Given this list of marker genes SPRY1, TOR1A, PSMC1, GATA2, CCT4, GDPD5, VPS45, ODF1, ITGAE, LGALS8, RRAGD, CASP7, ABCA4 (NCBI Gene Id 7815), IK, RASSF2, TTTY2, LIMK2, EPB41L1, CHRNB4, MTOR, SBF1, ETV4 (ETS variant transcription factor 4), NUP88, FERMT2, NUP205, KIF21B, U2AF2, PIK3C3, N4BP2L2, MLXIP, GFRA2, RHOA, DPF2, GJB3, CORO1A, CACTIN, COPS5, VAV2, MDN1, USP13, ZYX, EIF2S1, ACACB, CD79A, JUND, DLGAP4, ENSG00000275616, KRT4, PART1, CMC4, LYPD1, TMEM131, ACSL3, FOS, GAA (alpha glucosidase), SFTPD, STARD3, here is a description of the gene set: Integrin signaling signature in precursor B leukemia (PBL) cells: fibronectin (FN1) vs control treatment with poly-L-lysine. studied in species Homo sapiens The physical interactions between B cells and stromal cells from the lymphoid tissue microenvironment are critical to the survival of normal and malignant B cells. They are principally mediated by integrins expressed on B cells and counterreceptors on stromal cells. Specifically, alpha4beta1 integrin engagement rescues B cells from physiological or drug-induced apoptosis. Therefore, in order to understand the mechanisms by which integrins prevent apoptosis in leukemia B cells, we compared the temporal gene expression profiles induced by beta1-integrin ligation with fibronectin (Fn) or adhesion by poly-L-Lysine in serum-starved precursor B leukemia cells. Among the 38 selected differentially expressed genes, genes involved in adhesion (VAV2, EPB41L1, CORO1A), proliferation (FRAP1, CCT4), and intercellular communication (GJB3) were validated by real-time quantitative polymerase chain reaction (RT-Q-PCR). Gene expression modulation could also be validated at the protein level for 5 other genes. We show that integrin stimulation up-regulated FBI-1 expression but inhibited CD79a, Requiem, c-Fos, and caspase 7 induction when the cells underwent apoptosis. We further demonstrate that Fn stimulation also inhibits caspase 3 activation but increases XIAP and survivin expression. Moreover, integrin stimulation also prevents caspase activation induced by doxorubicin. Therefore, we identified genes modulated by adhesion of human precursor B leukemia cells that regulate proliferation and apoptosis, highlighting new pathways that might provide insights into future therapy aiming at targeting apoptosis of leukemia cells. from publication Astier AL, Xu R, Svoboda M, Hinds E, Munoz O, de Beaumont R, Crean CD, Gabig T, Freedman AS (PMID 12393420) Human Gene Set: ASTIER_INTEGRIN_SIGNALING